Given this list of marker genes Foxf1, Nckap1, Smad3, Sox17, Shh, Smad2, Gata4 (NCBI Gene Id 14463), Epb41l5, Notch1, Ctnnb1, Foxp4, Acvr2b, here is a description of the gene set: Mouse Gene Set: GOBP_FOREGUT_MORPHOGENESIS The process in which the anatomical structures of the foregut are generated and organized. species: Mus musculus